Given this list of marker genes ELOVL2, ELOVL5, ELOVL6, ELOVL7, HSD17B12, ELOVL4, ELOVL1, ELOVL3, here is a description of the gene set: Human Gene Set: GOBP_FATTY_ACID_ELONGATION_SATURATED_FATTY_ACID studied in species Homo sapiens Elongation of a saturated fatty acid chain.